The following is a description of a gene set: Pathway Definition from KEGG: SNCA* -| CxI -> Q Mutation-caused aberrant SNCA to electron transfer in Complex I. Pathway ID: N01042. Pathway type: Variant. Pathway class: nt06463 Parkinson disease. Human Gene Set: KEGG_MEDICUS_VARIANT_MUTATION_CAUSED_ABERRANT_SNCA_TO_ELECTRON_TRANSFER_IN_COMPLEX_I studied in species Homo sapiens, and this is the list of marker genes: NDUFC2, NDUFS8, NDUFA12, NDUFA5, NDUFB1, NDUFS3, NDUFS1, NDUFA3, NDUFC1, NDUFA6, MT-ND2, MT-ND3 (mitochondrially encoded NADH:ubiquinone oxidoreductase core subunit 3), NDUFS2, NDUFAB1, MT-ND6, NDUFA11, NDUFA13, NDUFB2, NDUFA1, NDUFB8, MT-ND4, NDUFB9, NDUFA10, NDUFB6, NDUFV3, NDUFA4, NDUFB4, SNCA, MT-ND1, NDUFB7, MT-ND5, NDUFV1, NDUFB11, NDUFB10, NDUFA9, NDUFS7, NDUFS5 (NADH:ubiquinone oxidoreductase subunit S5), NDUFS4, NDUFS6, NDUFB3, NDUFA2, NDUFB5, NDUFA7, NDUFA8, NDUFV2